The following is a description of a gene set: species: Homo sapiens Human Gene Set: GSE7831_CPG_VS_INFLUENZA_STIM_PDC_4H_DN CpG 1826 binds to Toll-like receptor (TLR)9, whereas influenza virus PR8 activates pDC via TLR7. Differential stimulation of pDCs is expected to result in unique activation mechanism(s) leading to a different phenotypically and functionally matured pDC We used microarrays to detail the global programme of gene expression underlying the maturation process of pDC activated with CpG 1826 and influenza virus PR8. We identified a distinct expression profile of upregulated immunomediators. Genes down-regulated in plasmacytoid dendritic cells (4h): CpG oligodeoxynucleotide 1826 versus influenza virus infection. from publication Iparraguirre A, Tobias JW, Hensley SE, Masek KS, Cavanagh LL, Rendl M, Hunter CA, Ertl HC, von Andrian UH, Weninger W (PMID 18029397), and this is the list of marker genes: CPZ, TEDC2, COMMD1, INSYN2B, XKR5, HECTD4, SLC6A8 (solute carrier family 6 member 8), HAND2, TEX48, NDUFS8, NODAL, OPTC, ERCC2, CLDN19, MICU1, SCRIB, NKG7, AVIL (NCBI Gene Id 80056), PKMYT1, KRT28, MTA3, PPIH, PPP1R3C, EVX2, F13B, CENPN, PNKD, SLC43A3, UPP2, RWDD2B, PFN3, CCL21, KRT6A, SLC25A39, ORC1, CLNK, LRAT, TRAF5, GFPT2, DDR2, HYOU1, RNF168, MXD3, SYCP1, ZNF513, CDCA5, C11orf71, ZCWPW2, CCNC, KIF23, SUV39H1, FBXO46 (NCBI Gene Id 23403), COX7A1, H1-4, LRRC26, MTCL3, DRD1, MYCL, COL2A1, MTRR, HAUS1, MEPE, MCTP2, CCT8L2, HASPIN, CEP128, RAC2, NSMCE1, RPS15A, RNF144A, SHMT1, KLHDC8A, WDR62, SNRPF, TONSL, SLC39A12, IL20, PDCD6IP, BTG4, PYCARD, FANK1, NUTF2, FGA, KIFC1, ZDHHC8, TOMM20L, PSMC3IP, RUNX3, ENKD1, FGF3 (NCBI Gene Id 2248), CCDC14, KCNN2, ANGPTL8, CDCA3, PLEKHF1, MTMR11, REEP5, CES1, AVPR2, STX8, MS4A3, SHLD1 (shieldin complex subunit 1), CKAP2L, LAIR1, SLC22A3, PDGFRB, NUDT14, SEMA4C, PTPDC1, CPA4, HCRTR1, RUNDC3B, UBL5, RNASEH2B (NCBI Gene Id 79621), KLRC3, DKK3, MPO, SLITRK2, SYN3, CD48, PIF1, FAM167A, ZMAT4, COL6A1, C9orf40, NAA38, N6AMT1, NDUFB2, SAP30, CTSG, SGO1, ATP5ME (ATP synthase membrane subunit e), SERPINB1, RPL39, FEN1, DTYMK, GNG13, FXN, LYPD6B, KCNN3, RNF166, MORN5, MBD4, MYO18B, CCHCR1, NLGN1, NANS, ASB9, GPX1, WEE2, RABGAP1L, LSM6, SLC22A2, CCDC18, BCO1, KCNG1, DNMT1, PRG2 (NCBI Gene Id 87065), FABP5, ARHGEF39, CUTA, FSCN2, PRR14, TMEM107, AMIGO2, TICRR, VIM, RBFOX1 (RNA binding fox-1 homolog 1), TMEM270, SPC24, TBXT, KRT13, MGP, CEP55, GRIK3, IFI30, RPL41, PLAU, STMN1 (stathmin 1), UHRF1, TUBB6, IQGAP3, JPT1, AGFG2, CIT, WDR90, DYNLL1, LHFPL5, ACCS, RAC3, SMPD5, ZIM3, COX7A2 (cytochrome c oxidase subunit 7A2), MAPK15, SGK2, UBE2A, COX5A, TSTD2, HCAR2 (NCBI Gene Id 338442), PLA2G2D